Given this list of marker genes Bax, Timm13, Letm1, Dnajc11, Apoo, Romo1, Agk, Micu1, Immt, Cox18, Timm10, Uqcc3, Maip1, Oma1, Tomm70a, Opa1, Pink1, Chchd3, Chchd6, Tmem11, Tmem126a, Oxa1l, Ndufa13, Slc25a46, Timm9, Myc, Afg3l2, Afg3l1, Trmt10b, Ghitm, Timm22, Tafazzin, Micos10, Cibar1, Bcs1l, Adck1, Apool (NCBI Gene Id 77997), Micos13, Timm29, Samm50, Chchd10, here is a description of the gene set: Mouse Gene Set: GOBP_INNER_MITOCHONDRIAL_MEMBRANE_ORGANIZATION A process that is carried out at the cellular level which results in the assembly, arrangement of constituent parts, or disassembly of the mitochondrial inner membrane. studied in species Mus musculus